The following is a description of a gene set: studied in species Mus musculus Mouse Gene Set: REACTOME_ESTROGEN_DEPENDENT_NUCLEAR_EVENTS_DOWNSTREAM_OF_ESR_MEMBRANE_SIGNALING Estrogen-dependent nuclear events downstream of ESR-membrane signaling, and this is the list of marker genes: Akt1, Foxo3, Cdkn1b, Creb1, Uhmk1, Akt2, Akt3, Mapk1, Xpo1